The following is a description of a gene set: studied in species Mus musculus Mouse Gene Set: GOBP_POSITIVE_REGULATION_OF_PROTEIN_MODIFICATION_PROCESS Any process that activates or increases the frequency, rate or extent of the covalent alteration of one or more amino acid residues within a protein., and this is the list of marker genes: C1qtnf9, Cdc25b, Ube2n, Strada, Dcun1d5, Eif2ak4, Dnajb2, Map4k2, Drd4, Sez6l, Adrb2, Neurl1a, Ralbp1, Dok7, Prom2 (prominin 2), Nfe2, Mapk9, Ccl19-ps1, Syap1, Agt, Igtp, Map3k7, Dvl1, Sumo2, Fam161a, Taok1, Cib1, Gdnf, Fzr1, Tsacc, Cryaa, Stub1, Wbp1l, Fbn1, Dab2ip, Sox9, Tesk1, Map3k10, Chga, Cdon, Tab1, Areg, Cd44, Mre11a, Ddr2, Ccdc88a, Fnta (NCBI Gene Id 14272), Tnfrsf18, Fgf18, Ip6k2, Pin1, Brms1, Fgd2, Dab2, Akt2, Prkaa2, Fbxo33, Dlg1 (NCBI Gene Id 320792), Fgfr3, Tnfsf18, Pxn, Eif4g3, Ep300, Pfn2, Ube2v1, Isl1, Reg3b, Adcy8, Ifng, Mapk15, Camk1, Ptpn5, Prickle1, Ptpn22, Rgcc, Bmal1, Kdr, Sema7a, Stradb (STE20-related kinase adaptor beta), Adipoq, Cdk5rap3 (NCBI Gene Id 97738), Ptpn1, Etaa1, Hipk2, Kif14, Edn3, Nupr1 (nuclear protein transcription regulator 1), Parp14, Ndn, Drd1, Ptprz1, Ang4, Maged1, Snx9, Wnt3a, Ccl19, Card14 (caspase recruitment domain family, member 14), Ube2s, Ntf3, Cd3e, Hspbp1, Il23a, Abi1, Nkx3-1, Ang2, Cdk5r1, Agrn, Tlr1, Kat5, Bdnf, Csnk1d, Egr1, Map2k7, Mastl, Aktip (AKT interacting protein), Trim65, Acvr2a, Cav2, Ube3a, Mprip, Birc3, Mta1, Il34, Lep (NCBI Gene Id 16846), Birc5, Htr2a, Map2k6, Ptger3, Spdya, Cblb, Ube2k, Itgb3, Eng, Topors, Pde4d, Cx3cr1, Map3k13, Tnfrsf1a, Edn1, Tes3-ps, Cd4, Dcun1d4, Ednra, Ptger4, Sema4d, Higd1a, Tnfsf11, Fnip1, Tgfa, Slc1a1, Cd24a, Chfr, Niban1, Svip, Raf1, Rnf40, Arid5a, Xiap, Ptpn11, Il1b, Wnt1, Pik3c3, Fanci, Camp, Il11, Map3k12, Ramp1, Abi2, Tpd52l1, Cdk2ap1rt, Ralb, Cripto, Pla2g6, Gpnmb, Mst1r, Ccr7, Prox1, Il6ra, Kndc1, Igf1, Fgd4, Sez6l2, Akap6, Cdk5r2, Mapk8, Ccn2, Ddrgk1, Tead1, Tgfb1, Prr5, Tnf, Gsk3a, Csf1, Fzd4, Nedd9, Lepr, Prr5l, Sqstm1, Tek, Gnas, Fam20a, Plpp3, Trpc5, Park7, Nox4, Fgf2, P2ry1, Csf3, Camkk2, Dcun1d1, Il6, Mapkap1, Nelfe, C3, Sesn2, Il2, Kras, Ddx3x, Fas, Src, Nelfa, Il4, Laptm5, Slc11a1, Snca, Ect2, Cnot9, Rbx1, Parp9, Ern1, Crkl, Rapgef3, Plaur, Ptk2b, Nek10, Bcl2, Map3k1, Pttg1ip, Aspscr1, Smyd3, Ccnd2, Flt1, Rap2a, Hamp, Trpc6, Hnf1a, Tirap, Hes1 (NCBI Gene Id 15205), Ncor2, Thbs1, Cntn1, Ednrb, Prkd1, Mycbp2, Tollip (NCBI Gene Id 80650), Rapgef2, Mad2l2, Adipor2, Golga2, Map2k3, Rgma, Pten, Ccny, Erbb4, Prnp, Flt4, Flt3, Zeb2, Cx3cl1, Sez6, Ceacam1, Il15, Rnf180, Grem1, Ube2srt, Notch2, Atf2, Ajuba, Tfrc, Itgb1bp1, Hpx, Brat1, Spn, P2rx7, Tnik, Hsp90aa1, App, Pibf1, Lck, Hbegf, Chek2, Gpr39, Rassf5, Iqgap3, Yes1, Tbc1d7, Fcer1a, Lrp4, Rassf1, Pias1, Tnip1, Ret, Gabarap, Musk, Fiz1, Itga5, Clip3, Rasa1, Senp2, Tbx1, Dip2a, Stil, Il18, Nrg1, Septin4, Kitl, Psen1, Huwe1, Jak2, Fyn, Rptor, Ercc6, Bag4, Erbb2 (erb-b2 receptor tyrosine kinase 2), Robo1, Icam1, Ppp1r15a, Pde5a, Trim23, Psmd10, Arrdc4, Tspyl5, Cdc20 (cell division cycle 20), Dusp19, Ang, Ttbk1, Ubb, Pomt1, Hras, Unc119, Ppia, Gas6, Cab39, Ripk2, Egfr, Rap2b, Jtb, Vegfb, Cartpt, Mmd, Agap2, Araf, Cntf, Rspo1, Ntrk1, Psrc1, Rap1a, Fancm, Map3k11, Hmgb1, Ern2 (NCBI Gene Id 26918), Avp, Prkca, Nhlrc1, Fgf7, Nod2, Efna5, Flt3l, Lats1, Vldlr, Ndfip1, Gab1, Ccnd1, Rassf2, Cul3, Klhl40, Arnt, Angpt4 (angiopoietin 4), Abl1, Grk3, Fbxw7, Pih1d1, Cep295, Vegfc, Rab3gap2 (RAB3 GTPase activating protein subunit 2), Trib1, Ccl19-ps5, Hspa5, Pink1, Pik3r3, Rictor, Bmp4, Slc8a2, Pik3ca, Cxcr4, Spsb4, Gata1, Limk2, Dcun1d3, Pef1, Phf23, Rasgrp1, Kit, Arl2bp, Bcl10, Hcls1, Ptk2 (PTK2 protein tyrosine kinase 2), Odam, Adra2c, Epo, Thpo, Gper1, Srcin1, Tnks1bp1, Btrc, Cd6, Amer1, Htr2b, Egf, Epha4, Sh2d1b1 (NCBI Gene Id 26904), Emp2, Ezh2, Il12b, Bmi1, Arhgef2, Chp1, Prkcd, Limch1, Cdk2ap1, Prkn, Irak1, Crh, Xbp1, Hdac6, Il12a, Zfp91, Tenm1, Prkaa1, Traf7, Pml, Inava, Angpt1, Erp29 (endoplasmic reticulum protein 29), Nmi, Gsk3b, Trib2, Mapk1, Fgf8, Magi3, Ogt, Zc3h12a, Sox4, Dnaja3, D1Pas1, Lyn, Rap2c, Cldn3, Cdkn1a, Abi3, Wfs1, Cd300ld3, Wnt5a, Skp2, Reln, Cck, Bcar3, Pdgfb, Rps2, Ang6, Bmp6, Map3k5, Ube2l3, Oprd1 (opioid receptor, delta 1), Fbh1, Tpx2, Bmp2, Ppp2ca, Rps3 (ribosomal protein S3), Vcp (NCBI Gene Id 269523), Ngf, Xrcc5, Cldn19, Ripk3, Stk11, Ifnb1, Nsmce3, Fgf4, Ube2d1, Pdcd10, Ctf1, Enpp2, Atg14, Csf1r, Adcy10, Ins1, Ccl19-ps6, Met, Chrna7, Atg10, Ccl19-ps4, Txn1, Rack1, Arrb2, Gprc5b, Dab1, Cdkn2a, Dip2b, Axin2 (axin 2), Irgm2, Adam9, Insr, Mlst8, Rhoa, Mt3, Arhgef5, Sphk1, Adra2a, Stox1, Rwdd3, Slc51b, Pdcd6, Hax1, Flot1, Tlr4, Cd74, Dvl3, Lif, Itln1, Vegfa, Fmr1, Cd80, Aimp2, Cav1, Hdac2, Mapk8ip3, Fndc1, Pias4, Wdr24, Chi3l1, Stk4, Traf4, Tlr6, Bmpr2, Ndfip2, Pdgfa (NCBI Gene Id 18590), Lrp8, Osbp, Mapre3, Tspan9, Spatc1l, Pik3r1 (phosphoinositide-3-kinase regulatory subunit 1), Nbn, Il24 (interleukin 24), Sash1, Ehd4, Tab2, Phip, Tnfrsf14, Nos1, Csf2, Pecam1 (platelet/endothelial cell adhesion molecule 1), Mmp9, Hdac4, Adcyap1, Il3, Ccl19-ps3, Aplnr, Mavs, Tnfrsf11a, Map2k1, Rarres2, Ntrk3, Lrrk1, Mrnip (MRN complex interacting protein), Ltf, Vtn, Pin1rt1, Paxip1, Adra2b, Atg7, Fnip2, Ighm, Map3k4, Anxa2, Tank, Peli2, Cln3, Crebl2, Adtrp, Il13, Wnk4 (WNK lysine deficient protein kinase 4), Clcf1, Hmga2, Dynapl1, Plk1, Ager, Fzd5, Tnk2, Dvl2, Hes5, Dynap, Nop53, Fgfr1, Nptn, Pik3cg, Pak2, Adnp, Hspa2, Gfra1, Cass4, Traf6, Sirt1, Hsf1, Ucn, Wdfy2 (NCBI Gene Id 268752), Hdac3, Inhba, Wdr59, Aif1, Fam107a, Clec7a, Rchy1, Rac1, Prlr, F2, Ppp2r3c, Ntrk2, Rock2, Wnk3, Arrb1, Pik3r5, Card10, Npm1, S1pr2, Crlf1, Arrdc3, Cenpe, Skp1, Bank1, Taok3, Eif4g1, Cdkn1b, Dgkq, Iqgap1, Dcun1d2, Sprtn, Faxdc2, Lrrn3, Commd1, Mob2, Rab3gap1, Fgf10, Mul1, Kdm1a, Nnmt, Nscme3l, Tm9sf5, Dock7, Efna1, Il5, Pomt2, Akap11, Braf (NCBI Gene Id 97330), Ccnd3, Akt1, Trim6, Peli1, Prkag2, Cacul1, Mtor, Cemip, Ccl5, Fzd8, Ilk, Rasd2 (NCBI Gene Id 75141), Pim1, Ripk1, Als2, Map2k2, Ticam1, Osm, Rbx1-ps, Dtnbp1, Irgm1, Syk, Ptprc, Reg1, Traf2, Birc7, Pak1, Daxx, Trabd2b, Rb1cc1, Il6st, Tom1l1, Pdgfra, Pdgfc, Map2k4, Fgf15 (NCBI Gene Id 14170), Trem2, Pdgfrb, Cd40, Spry2, Derl1, Itgb1, Rnf111, Rad50, Sae1, Thbs4, Cdk5, Lrrk2, Ereg (epiregulin), Fgf1, Vangl2, Tcim, Cry1, Ccn1, Ins2, Nrxn1 (NCBI Gene Id 68042), Chrna3, Trib3, Fbxo4, Clspn, Cdc14b (CDC14 cell division cycle 14B), Il21, Axin1, Pias3, Cops8, Mif, Ahrr, Il31ra, Fzd1, Adam17, Akap5, Gba1, Marchf7, Ctnnd1, Tcl1 (T cell lymphoma breakpoint 1), Ube2v2, Mmd2, Spdye4a, Lilra5, Akap9, Ang5, Gnl3, Ubqln1, Birc2, Acvr1, Sh2d1b2, Pik3r6, Tgfb2, Xrcc6, Hamp2, Mydgf, Uba2, Slco3a1, Cspg4